Given this list of marker genes Il9, Il7r, Blnk, Igtp, Il17d, Ifrd1, Xcl1, Il12b, Il4, Ccl2, Stat4, Ccl6, Pias3 (NCBI Gene Id 54605), Vpreb3, Il13, Cx3cl1, Cxcl9, Bok, Tlr11 (toll-like receptor 11), Ifnar1, Nfkb1, Il23r, Il2rg, Ccl4, Lcp2, Il6, Cxcl10, Ccr7, Ly6d, Ifnb1, Pias2, Il4i1, Irf7, here is a description of the gene set: Selected genes with immunologic function which were reciprocally changed in evasion and tolerogenic tumor models. Mouse Gene Set: WORSCHECH_TUMOR_EVASION_AND_TOLEROGENICITY_UP species: Mus musculus from publication Worschech A, Kmieciak M, Knutson KL, Bear HD, Szalay AA, Wang E, Marincola FM, Manjili MH (PMID 18381452) We have previously shown T-cell-mediated rejection of the neu-overexpressing mammary carcinoma cells (MMC) in wild-type FVB mice. However, following rejection of primary tumors, a fraction of animals experienced a recurrence of a neu antigen-negative variant (ANV) of MMC (tumor evasion model) after a long latency period. In the present study, we determined that T cells derived from wild-type FVB mice can specifically recognize MMC by secreting IFN-gamma and can induce apoptosis of MMC in vitro. Neu transgenic (FVBN202) mice develop spontaneous tumors and cannot reject it (tumor tolerance model). To dissect the mechanisms associated with rejection or tolerance of MMC tumors, we compared transcriptional patterns within the tumor microenvironment of MMC undergoing rejection with those that resisted it either because of tumor evasion/antigen loss recurrence (ANV tumors) or because of intrinsic tolerance mechanisms displayed by the transgenic mice. Gene profiling confirmed that immune rejection is primarily mediated through activation of IFN-stimulated genes and T-cell effector mechanisms. The tumor evasion model showed combined activation of Th1 and Th2 with a deviation toward Th2 and humoral immune responses that failed to achieve rejection likely because of lack of target antigen. Interestingly, the tumor tolerance model instead displayed immune suppression pathways through activation of regulatory mechanisms that included in particular the overexpression of interleukin-10 (IL-10), IL-10 receptor, and suppressor of cytokine signaling (SOCS)-1 and SOCS-3. These data provide a road map for the identification of novel biomarkers of immune responsiveness in clinical trials.